The following is a description of a gene set: species: Homo sapiens Human Gene Set: LET_7B_5P from publication Chen Y, Wang X (PMID 31504780) Genes predicted to be targets of miRBase v22 microRNA hsa-let-7b-5p in miRDB v6.0 with MirTarget v4 prediction scores > 80 (high confidence targets)., and this is the list of marker genes: NPEPL1, MASP1, ELF4, DTX4, SMC1A, AMT, CNOT6L, TNFSF9, MAP3K9, TMEM121B, COL4A2, KDM3A, IGF2BP3, HOOK1, LPGAT1, YOD1, SLC35D2, GAS7, IGDCC4, NME6, CERCAM, HDX, CCND2, ADAMTS15, STIMATE, PDE12, PLEKHA8, ACTA1, SEMA4G, CARNMT1, HIC2, ANKRA2, PCDH19, EPHA4, STX3, KLHL31, ATL2, TSEN34, PPP1R16B, RSPO2, LEPROTL1, SKIL, GALC, FIGN, MEF2C, XK, GATM, ZBTB8B, SLC22A23 (solute carrier family 22 member 23), BEND4, GABBR2, RAB8B, RIMOC1, AHCTF1, RALB, CPA4, ONECUT2, DLC1, SPRYD4, TGFBR1, SLC10A7 (solute carrier family 10 member 7), NGF, PDPR, AGO4, CLCN5, LAMP2, SEMA4C, IL13, SLF2, WDR37, ZNF710, PAPPA, OSBPL3, EDN1, DDTL, ARK2C, RGS6, GJC1, ARMT1, CBX5, PTAFR, COIL, CD59, COL5A2, CPEB3, MED8, ZNF280B, EIF4G2, BZW1, DTX2, ZNF644, ADRB3, HAND1, CADM2, USP38, GRPEL2, HOXA1, INSR, IGDCC3, MAP3K1, KIAA1958, CEP135, TMEM65, ADAMTS8, SRGAP1, RANBP2, TET3, EFHD2, DNA2, MEIS2, KLF9 (NCBI Gene Id 687), FRMD4B, KCTD17, SENP2, RBFOX2, PLEKHG6 (NCBI Gene Id 55200), COL4A6, CRTAM, ZSWIM5, XYLT1, SMARCAD1, SLC20A1, CLP1, FAXC, ARHGAP28, PGRMC1, VIRMA, CD164, MMS22L, CCL7, STRBP, SLC31A2, CDC34, AKAP6, DPP6, SOCS4, E2F2, DPH3, DNAJC1, TRIM67, AP1S1, PBX1, BEGAIN, OPA3, UHRF2, IRS2, PALD1, USP44, SENP5, GAN, SESTD1, ATOSB, NIPAL4, ZNF583, NME4, HECTD2, RICTOR, C18orf21, PEX11B, UTRN, COL1A2, GTF2I, DMD, DDI2, LINGO1, SLC38A9, PRTG, ADRB2, TMEM234, MRS2, SCD, DHX57, FASLG, CEP120, SCN11A, HIP1, GDF6, FZD4, TAF9B, CERT1, PTPRD, OSMR (NCBI Gene Id 9180), TMOD2, LIN28A, C8orf58 (chromosome 8 open reading frame 58), FNDC3A, B3GNT7, UGCG, MAP4K3 (NCBI Gene Id 8491), NKAPD1, SALL4, CDC25A, GXYLT1, PIGA, PBX2, PARP8, CPEB1, LBR, MIB1, NAP1L1, SLC2A12, ZNF689, PABIR1, E2F5, POLL, EEA1, TRIM71, SUB1, STK40, GYG2, PXDN, HSPA14, KLF8, POGLUT1, IGF1R, PEG10, ZNF322, TMPRSS2, FNIP2, POLR3D, ERCC6, PLPP5, RASGRP1, RGS16, HAS2, NHLRC3, SRD5A3, RUFY3, SNX30, AGAP1, DDX19A, GPR26, THRSP, EDEM3, CDKN1A, FZD3, HIF1AN, ZCCHC9, ACER2, PARPBP, GALNT1, ZBP1 (NCBI Gene Id 81030), MARS2, MFSD4A, PCGF3, ENTREP2, DCUN1D2, COL3A1, GFM2, NRAS, NYNRIN, SNX16, PLXNC1, SIGLEC14, YPEL2, LRIG2, ERO1A, FGD6, VCF1, DNAJA2, AEN, CLDN12, KCNC2, GNPTAB, KCTD21, PRSS22, SLC5A9, SIGLEC5, BSN, IQCB1, GPCPD1, FAM135A, POGZ, ENTPD7, ZBTB5, CCNJ, C15orf39, EEF2K, PRPF38B, TGFBR3, ARG2, TMC7, ARID3B, TMPPE, HDLBP, CHD4, NPHP3 (nephrocystin 3), ZNF275, DIP2A, PLPP6, CNTRL, GOLT1B, BIN3, PIK3IP1, XRN1, STARD9 (StAR related lipid transfer domain containing 9), RFX6, CASP3, PRLR, ASAP1, ZFYVE26, WNT9B, MBD2, FIGNL2, ELP1, FGF11, GCNT4, GPATCH2, ATP8B4, MAPK8, HMGA2, IGF2BP2, ABCC5, FBXL12, MDM4, RAB11FIP4, PLAGL2, PLA2G3, NEK3, SCN4B, HOXD1, VAV3, COL27A1, ARID3A, IKZF2, PDP2, DVL3, ACVR2A, TSPEAR, AMOT, ATP2A2, THOC2, STARD3NL, GNG5, LIPT2, LIN28B, ACSL6, DUSP1, KIAA0930, XKR8, ERCC4, ARHGEF38, RDX, SMIM3, E2F6, TRANK1, ABCB9, COL4A1 (collagen type IV alpha 1 chain), ZNF516, PXT1, RNF20, LRIG3, LIPH, ZNF512B, TMEM167A, FRAS1, ZNF784, C14orf28, CEMIP2, SFMBT1, SLC16A9, ABL2, PLEKHO1, CLDN16, NR6A1, TBKBP1, KCNJ11, ITGB3, SLC5A6, PPP1R15B, FNIP1, ESR2, DDX19B, LIMD2, SALL3, DUSP22, MYCN (MYCN proto-oncogene, bHLH transcription factor), CPEB2, IGF2BP1 (insulin like growth factor 2 mRNA binding protein 1), ACVR1C, SDK1, MTDH, DNAAF9, B4GAT1, SLC25A27, BACH1, ABT1, KLHDC8B, MAPK6, GALNT2, USP24, APBB3, STARD13, DCAF15, TTLL4 (tubulin tyrosine ligase like 4), DLST, FNDC3B, TECPR2, ARL5A, C19orf47, PLXND1, PBX3, IMPG2